Given this list of marker genes Map2k3, Kat7, Mapk13, Map2k4, Cdt1, Map2k6, here is a description of the gene set: species: Mus musculus Mouse Gene Set: GOBP_RESPONSE_TO_SORBITOL Any process that results in a change in state or activity of a cell or an organism (in terms of movement, secretion, enzyme production, gene expression, etc.) as a result of a sorbitol stimulus.